The following is a description of a gene set: A cytoplasmic, membrane bound vesicle that is capable of fusing to the plasma membrane to release its contents into the extracellular space. studied in species Homo sapiens Human Gene Set: GOCC_SECRETORY_VESICLE, and this is the list of marker genes: FPR2, TEX264, DEFA4, SPAG9, DOK3, B4GALT1, CLTB, PGLYRP1, CD68, SLC17A7, LAMP1, LILRA3, SLC6A9, KLK3, SLC11A1, OSCAR (osteoclast associated Ig-like receptor), SNAP23, TFF3, TMEM179B, IQUB, DSG1, COMMD3, AMPH, DCST2 (NCBI Gene Id 127579), CLEC4C (NCBI Gene Id 63328), MROH2B, NPC2, ARL8A, OSBP2, PATE4, NDUFC2, CD47, ITGB3, CMA1, PGRMC1, CAB39, COPS4, TRAPPC4, TH, ATP8B4, FGA, SPARC, TTR, GSDMD, TSSK2, PLD1, SYPL1, PRSS37, SSH2, SIRPA (signal regulatory protein alpha), THBS1, TMPRSS12, PRSS55, SLCO4C1, KIAA1210, FRK, PSMA5, CBARP, SLC18A1, MCEMP1, XRCC5, GLIPR1, RAB27B, PSMD12, RAB8B, BRCA2 (NCBI Gene Id 82716), SERPINF2, NPY, WFS1, AGPAT2, ITGA2B, IL1B, DEGS1, ATP2B1, SLC17A9, TAFA4, SYT9 (synaptotagmin 9), LAMP2, SYT3, GOLGA1, GSTP1, ITGAX, ADRB2, PLCB2, FUCA2, EDN1, CST3, CPNE3, POMT1, POMC, NOTCH1 (notch receptor 1), STON1, NPPC, KNG1, FRMPD3, NLRP5, RETN, CDK13 (NCBI Gene Id 8621), GABBR1, ITGAV, IST1, ILF2, THBS2 (thrombospondin 2), SEMA4C, ALDOA, SLC17A6, SDCBP (NCBI Gene Id 6386), AOC1, SERPING1, RAB11FIP5, LTA4H, ANXA3, LYZL4, APAF1, SNAP29 (synaptosome associated protein 29), NKD2, VPS33B, PSMC3, SLC30A10, GCG, SERPINB6 (serpin family B member 6), ANXA13, CHIT1, LYZL6, CDC37L1, CATSPER4, PLA2G10, CYLC1, ROCK1, PPT1, SYNDIG1, TMEM210, EEF1A1, SELL, SLC35F1, KCNAB2, ANGPTL6, SV2B, IQCF1, HCRT, MFGE8, DVL1, NHLRC3, DYNC1LI1, MTMR2, ANXA11, TIMP1, CLCN4, PAK2, NHLRC2, HP, CTSS, MT3, F8, GNAI2, P2RX2, LYZ, TSSK4, TOLLIP, COPS5, PRDX6, RAB10, SST, PHAF1, C5AR1, GLA, RAP1A, SLC2A8, LAMP3, VDAC2, ACRBP, RAB9B, PYGL, ARG1, MAGED2, LOXL1, SYT17, RHOG, PADI6, LEFTY2, LILRB3, RNASE2, VAMP8, CPE, CLK3, SCG2, TRH, DYSF (dysferlin, NCBI Gene Id 8291), KLK14, PRKN, ATP6V0A1, NTF3, RAB13, SEPTIN8, CRACR2A, PCSK4, GAA (NCBI Gene Id 2548), ABCA13, ATP6V1B1, ABCC8, DOC2A, STOM, SYNGR4, STX10, STX7, CRHBP, LGI3, PCSK2, SYT15, GTPBP2, ACAA1, RAB31, KLK5, PTPRC, FAM170B, PYGB, C3, UNC13D, SH3GL3, PICALM, PTPRN, SV2C, FAM220A, CHRNB4, ZG16, CKAP4, SYTL5, ITPR3 (inositol 1,4,5-trisphosphate receptor type 3), DSN1, MGAM, CRCP, TMEM30A, DNM1, RNASE3, DNM1L, CEACAM3, ALB, HEBP2, SYP, ACTN4, SLC2A13, CSNK2A2, DNAJC13, GRN, RAB3D, NCKAP1L, PRKACA, CHI3L1 (NCBI Gene Id 7836), MNDA, ACLY, PSMD7, PRSS3, S100A11, TICAM2, PROS1, BTBD8, NME2, GIP, SLC6A5, KLK7 (NCBI Gene Id 5650), PRSS58, LGALS3, SEPTIN6, STXBP3, CLCN3, CAV2, SELP, OPRD1, UNC13C, SNAP91, XRCC6, LRGUK, PCYOX1L, SLPI, ALOX5, VEGFB, SPAM1, ATP6V0C, PSMD3, VAMP3, RAB40C, CCDC136, SPRR2A, NCF2, LRRC7, CD53, SPACA1, F5, GKN1, AZU1, AP3M2, SYNGR2, RAB27A, SKIL, FN1, UBE3A, SPAG17, PCSK1, AGA, SPAG8, CALR, CD33, IRAG2, EPX, PRTN3, KLK8, SLC40A1, GUSB, RAC1, ITPR1, ICA1, IQSEC1, RAB14, SPACA3, STX1A, KLK6, TRAPPC1, GHRL (NCBI Gene Id 51738), SYT11, RAB12, CEACAM1, PRKCD, SCCPDH, B2M, RNF112, GRIA1, OTOF, CD44, VAPA, LACRT, CTSA, MMRN1, NTF4, SERPINE2, DMXL2, TRIP11, PTPRN2, KLK1, SCAMP5, ATP6V0E2, GAL, SERPINA3, VAMP2, KRT1, SERPINA4, PDGFA (platelet derived growth factor subunit A), ATP6AP1, PKDREJ, SYT6, RAB3A, SPP2, TBC1D10C, ALAD, SPACA5B, GGH, CD59, PKP1 (plakophilin 1), FTH1, DNASE1L1, BDNF, MGST1, TUBA8, PRRT1, RHOF, CLEC4D, KLK4, YPEL5, CTSW, ADA2, SPINK5, DEFA5, ATP6V1H, FGB, SNCA, TRPM2, SLC27A2, TIMP3, VEGFA, SYPL2, CYSTM1, ATP6V1G1, TRIM9 (NCBI Gene Id 23206), COL1A1, PGM2, ITGAM, ADAM15, APRT, KLK11, RAB8A, ITIH4, MORN3, PPBP, ADGRG3 (NCBI Gene Id 58870), S100P, PTPRJ, CTNNA1, PPFIA3, KLK9, VNN1, SEPTIN1, ELANE, NFKB1, SRP14, SCNN1A, SLC9A4, SYT13, HRG, BIN2, PRRT2, ATM, ACTL7A, IGF1, TMEM95, PSMD6, ISLR, CYB5R1, HYAL3, TCN1, RCBTB2, SYTL4, APOLD1, UNC13A, ITGAL, LY6G6F, PSMD13, MAPK14, PTPRS, VCL, ACP3, GLIPR1L1 (NCBI Gene Id 256710), PRSS2, RAB40AL, SYNGR3 (NCBI Gene Id 9143), IZUMO3, LAMTOR1, SLC6A2, HLA-B, SLIRP, HSP90AB1, VCP, RAB37, TMEM190, C3AR1, PCSK1N, KLK10, DGAT1, SEPTIN5, FTL, SYT8, SERPINB12, PSMD1, DMBT1, TOM1, SMPD1, GDI2, ABCA12, SELENOP, TMEM230, DDOST, SYT7, FGL2, TMSB4X, SLC2A4, KLK2, CMTM6, HPSE, GNS, IL4I1, FER1L5, CHGA, RAB26, ARPC2, VTI1B, FCN1, ATP6V1D, PSEN1, CD9, ROGDI, PTPRB, ANXA4, DERA, DPYSL3, TEX22, TSNARE1, TGFB2, PTPN6, SFTPC, PSEN2, GNAT3, CR1, SLC35D3, FZD8, CTTNBP2, IGF2, SLC32A1, CLEC3B, MYOF, PTX3, MYRIP, DNAJC5, CFAP119 (cilia and flagella associated protein 119), STXBP5, CADPS, DRD2, TLR2, MANBA, ANPEP, RAB5B, JUP, SRI, PNLIPRP2, VPS13A, CLEC5A, CFAP65, SEPTIN4, RAB40B, KIF1B, VWF, RACGAP1, S100A8, CANT1, MYO5A, SLC17A5, VAMP7, RAP2B, PLA2G2A, OXT (oxytocin/neurophysin I prepropeptide), EXOC3, TCP11, BORCS5, CYBB, SLC44A2, IMPDH1, PIGR, TMEM63A, ITPR2, IGF2R, ANO6, SPATA1, CD109, HRNR, CFD, FGG, HBB, ARPC5, ENKUR, DSC1, PDAP1, LTF, CPNE1, PHF24, ATP11B, DEFA3, HSPA6, RAB11A (RAB11A, member RAS oncogene family), VEZT (vezatin, adherens junctions transmembrane protein), APOA1, HEXB (NCBI Gene Id 3074), CSTB, ECM1, PECAM1 (platelet and endothelial cell adhesion molecule 1), QPCT, VPS13B, APLP2 (amyloid beta precursor like protein 2), TMEM63B, FABP5, ADM, SYT10 (NCBI Gene Id 341359), DLG4, RAB18, LAIR1, SPESP1, SERPINB1, SLC30A3, VEGFC, RAB2B, HVCN1, TUBB4B, ATP11A, PRG3, COMMD9, VAMP1, HEXA, TMEM184A, PSMD11, MMP8, CD63, STING1, STK31, CALCA, DOCK2, CAT, CDK16, KNL1, SLC4A8, GSN, FERMT3, CFP, HAP1, PFKL, SERPINB3, KPNB1, DENND4C, RAB2A, CREG1, APOOL, TAC1, CXCR2 (NCBI Gene Id 3579), ATP6V0A4, CD55, TMEM163, SFTPB, FSTL4, SFTPA2, PSMC2, ACTR1B, ADRB1, APP, SYT5, DBH, CATSPER3, OLR1, COPB1, SYNGR1, GHDC, HGF, TF, SNAPIN, CCL28, TSPAN14, HSP90AA1, NDEL1, NCSTN, LHFPL2, PSMA2 (proteasome 20S subunit alpha 2), TBXA2R, SNCAIP, CAMP, PSMB1, ATP6V1B2, SIGLEC5, APOH, CAV1, PRCP, VEGFD, TMBIM1, CA4, SYNPR, SERPINA1 (serpin family A member 1), ASAH1, STX3, IMPDH2, CD177, SLC18A2, CAPN11, DKKL1, PCDH7, TNFRSF1B, MS4A3, AP1M1, CLTA, STX6, PRSS57 (serine protease 57), BPI, MMP9, BACE1, CXCR1, CPA3, SFTA3, SIGLEC14, ATP6V1E1, SLC30A5, SYCN, MOXD2P, LAMTOR2, OSTF1, KIF1A, GM2A, RAB3B, SPACA4, S100A9, HSPA1B, ATP6V0D1, SNX10, AP2B1, HPS4, A2M, PAFAH1B2, ACR, EBAG9 (NCBI Gene Id 9166), RAB4A (NCBI Gene Id 5867), MCTP1, STXBP1, PHACTR2, EEF2, PLAUR, SYN1, TCIRG1 (T cell immune regulator 1, ATPase H+ transporting V0 subunit a3), SPTAN1, SVOP, ATP8A1, AP2M1, GMFG, PLAU, PPFIA2, ZPBP, CIMIP4, ARHGAP9, PKM, PLAC8, CPLX3, LRG1, SYN2, SLC17A8, PSMB7, BRI3 (NCBI Gene Id 25798), SPACA9, HLA-C, KCMF1, CD36, ATP6V0A2, MAN2B1, TMC6, DBNL, QSOX1, GPR151, RAP1B, DLD, MOSPD2, TBC1D21, INS, SYT4, MVP, TMED10, ANXA2, BRSK1, TMPRSS4, FCGR3B, NAPSA, CTSD, SYTL3, AKAP3, CEACAM6, EQTN, HSPA8, LCN2, BICD1, DIAPH1 (NCBI Gene Id 1729), SERPINB10, BST1 (bone marrow stromal cell antigen 1), ABHD2, SLC5A7, RAP2C, SYN3, LPCAT1, AP1B1, FLG2, ECRG4, MLEC (malectin), SLC9A8, FGR, SURF4, LRRK2, BSG, PRDX4, GCA, CD300A, CYB5R3, PSAP, MAGT1, IZUMO1, ADAM8, CHGB, FUCA1, SEPTIN14, HUWE1, ARSA, UBR4, CACNA2D1 (NCBI Gene Id 781), CYFIP1, SIGLEC9, TGFB3, PAM, C1orf35, PLA1A, KLK12, PGM1, HK3, HSPA1A, RAB7A, RAB3C, MIF, KLK13, RABAC1, CTSG, PICK1, RNASET2, TMED2 (NCBI Gene Id 10959), MMP25, ATP6V1G2, TXNDC8, SPAG6, SV2A, ATAD3B, ALDH3B1, PNP, ANXA7, AMPD3, SPINK2, TOR1A (torsin family 1 member A), ZPBP2, CCT8, DSP, SLC30A2, GRIN2A, CRH, GABRA2, ORM2, KRTDAP, PYCARD, IQGAP1, LILRB2, VTI1A, CLCN5, KIRREL3, CARTPT, NFAM1, DCST1 (DC-STAMP domain containing 1), NBEAL2, TRIM36, SPACA6, IQGAP2, MCTP2, PADI2, SYT1, PA2G4, PSMD2, ACTL9, ARC, TMED9, MFF (NCBI Gene Id 56947), TIMP2, GPR84, DGKI, IFT74, STX4, FAM209B, CEP131, TPRG1L, NIT2, P2RX1, ALDOC, ACRV1, CSNK2B, VPS13C, RAB11B, HILPDA, USP8, CACFD1, PDYN, UNC13B, ATP6AP2, NEU1, CALML5, ABCC4, TGFB1, FCER1G (Fc epsilon receptor Ig), FCGR2A, ASTL, ICA1L, CTSB, STK11IP, SERPINA5 (serpin family A member 5), MME, CYB561, SPACA7, TCP11X1, ARMC8 (NCBI Gene Id 29067), ATP6V1G3, CTSC, EPPIN, ATP6V1C1, CNN2, TMT1A, MYH9, GYG1, GRIN1, PDGFB, F13A1, ATP6V1F, PLG, ECE1, SLC30A8, S100A7, GRP, COTL1, SLC6A17, IDH1, DPP7, AGL, FAF2, CRISPLD2, LGALS3BP, CCT2, PTAFR, SFTPA1, ACTN1, DYNLL1, SCG5, KLK15, BAIAP2, TXNDC5, ORM1, VPS35L, STK10, CAP1, OLFM4, ENPP4, KCNK9, ATG7, AP2A1, SOD1, VAT1, TEKT3, CTSL (NCBI Gene Id 1514), MAPK1, SIRPB1, ITGB2, EXOC3L1, RARRES2, OPRK1, CRISP3, TUBB, ABCA3, LAMP5, RAB24, RAB5C, CLEC12A, DPEP3, OLA1, LY6K, ITGA1, GP2, ADAM10, DDX3X, RAB6A, SVIP, NPFF, CT55, SPATA16, TMEM225, CTSZ, RND2, STXBP2, TOR4A, ZNRF1, FLOT2, DEFA1, CCDC62, TARM1, BAIAP3, ORMDL3, HMGB1, BPIFA2, ATP8B3, TMX3, FNDC3A, KIT, CTSH, CALM3, MOXD1, STX12, PRKG1, HMOX2, CXCL1, APEH, SPACA5, SYT12, GHRHR, APBA1, STBD1, PF4, TEX101, AP3S2, STON2, DTNBP1, PRG2, SERPINI1, MPO, CD93, NFASC (neurofascin), CD58, FPR1, PDXK, SLC15A4, TYROBP, SYTL2, DEFA1B, HSPD1 (NCBI Gene Id 56733), PPIE, ITIH3, TSSK1B, GALNS, SNAP25, GIPC1, GAS6, IFT20, SYTL1, CYRIB, FOLR3, HGSNAT, ATP6V1E2, CLCA1 (chloride channel accessory 1), ACTR2 (actin related protein 2), CAND1, SYT2, FCAR, CD46, TCP1, SCG3, DYNC1H1, PPIA, AHSG, BSN, CLU, C6orf120, APH1A, HLA-H, CAPN1, LAMTOR3, TNFAIP6, SRGN, BST2, GOLGA7, FAM3C, ACTN2, TCP11X2, AP2A2, ERP44, RPH3A, SLC9B2, PDE4B, CYBA, PGAM1, CEACAM8, CLN3, ACTR10, GPI, SERPINE1, DYNLT1, CEP290, DNASE1, ATP6V1A (NCBI Gene Id 523), SLC18B1, CUZD1, ADGRE3, TREML1, NAPRT, DYNLT4, RAB44, CXADR, PLAT, CPPED1, PTGES2, RAB4B, PSMD14, GLB1, CD14, BIN1, CALCR, ANP32E, PENK, SLC2A5, NGF, SLC2A3, AVP, SLC35G2, RAB5A, NRAS, SCGB1A1, PLEKHO2, ARSB, DNAJC3, CABS1, RAB40A, SLC18A3, S100A12, GARS1, CDA, ARHGAP45, VPS45, A1BG, SPX, DISC1, SPACDR, ACTRT1, SCAMP1, BCL2L1, ADGRE5, PARK7, RHOA, MORN2, EGF, STX16